Given this list of marker genes Ercc2, Rad50, Mlh1, Zscan4c, Ankle1, Terf2, Blm (NCBI Gene Id 12144), here is a description of the gene set: species: Mus musculus Any process that modulates the frequency, rate or extent of DNA recombination during mitosis. Mouse Gene Set: GOBP_REGULATION_OF_MITOTIC_RECOMBINATION